The following is a description of a gene set: studied in species Mus musculus Mouse Gene Set: GOBP_POSITIVE_REGULATION_OF_ISOTYPE_SWITCHING_TO_IGG_ISOTYPES Any process that activates or increases the frequency, rate or extent of isotype switching to IgG isotypes., and this is the list of marker genes: Pagr1a, Mlh1, Pms2, Il2, Atad5, Cd28, Il4, Ptprc, Tbx21, Ifng, Paxip1, Cd40, Msh2